Given this list of marker genes ABCA12, here is a description of the gene set: ATP-binding cassette sub-family A member 12 (ABCA12) is thought to function as an epidermal keratinocyte lipid transporter. These lipids form extracellular lipid layers in the stratum corneum of the epidermis, essential for skin barrier function. Defects in ABCA12 results in the loss of the skin lipid barrier, leading to autosomal recessive congenital ichthyosis 4B (ARCI4B; MIM:242500, aka harlequin ichthyosis, HI). ARCI4B shows the most severe phenotype of the congenital ichthyoses, with newborns having a thick covering of armour-like scales. The skin dries out to form hard diamond-shaped plaques separated by fissures. Affected babies are often born prematurely and rarely survive the perinatal period. part of: ABC transporter disorders Reactome Pathway: Defective ABCA12 causes ARCI4B studied in species Homo sapiens